The following is a description of a gene set: Human Gene Set: HP_METAMORPHOPSIA studied in species Homo sapiens A visual anomaly in which images appear distorted. A grid of straight lines appears wavy and parts of the grid may appear blank. Metamorphopsia, and this is the list of marker genes: GNAQ, UNC119, RPGR, CACNA1F, TTLL5, PROM1, GUCY2D, CFH, GUCA1A, ENPP1, SEMA4A, ABCA4, PRRT2, PITPNM3, SF3B1, RPGRIP1, RAB28, EFEMP1, ADAM9, CFI, TLCD3B, SCN1A, CACNA2D4, NMNAT1 (nicotinamide nucleotide adenylyltransferase 1), ATF6, RIMS1, OPN1MW, PRPH2, CACNA1A, CDHR1, CFAP418, BAP1, OPN1LW, CNGA3, CYSLTR2, DRAM2, CRX, RAX2, ABCC6, POC1B, GNA11, BEST1, AIPL1, ATP1A2, CFAP410